The following is a description of a gene set: Genes predicted to be targets of miRBase v22 microRNA mmu_miR_7241_5p in miRDB v6.0 with MirTarget v4 prediction scores > 80 (high confidence targets). studied in species Mus musculus Mouse Gene Set: MIR_7241_5P from publication Chen Y, Wang X (PMID 31504780), and this is the list of marker genes: Ttpal (tocopherol (alpha) transfer protein-like), Zranb2 (zinc finger, RAN-binding domain containing 2), Sass6, H3f3a, Slc26a11, Ssbp3, Cbfb, Cdk6, Tspan2, Nxnl2, Lrrc4c, Pcdh7, Camsap2, Rbak, Med13, Ift43, Rgs7bp, Ube2b, Vps35, Ptbp1, Kdm7a, Tlcd4, Kpna4, Map2k6, Wnk2, Taok1, Vamp4, Calml3, Klf15, Eif2s2, Septin7, Lims1, Scn8a, Clcn5 (NCBI Gene Id 97624), Crmp1, Dpyd, Syt4, Stxbp5l, Stimate (NCBI Gene Id 74250), Dnajb11 (NCBI Gene Id 67838), Sall4, Fam98a, Gpr158, Prkacb, Rfx3, Phospho2, Fam168a, Irx2, Ryr2, H3f5, Nbl1, Mbtd1, Zbtb43, D630045J12Rik, Igf1r, Mdga2, Hpse, Zfp143, Gatad2a, Rtn4, Mon2, Tmem86a, Oog3, Dach1 (NCBI Gene Id 353035), Rictor, Senp5, Smarcd2, Lnpk, Sun1, Rock1, Med11, Pcdh8, Gata6, Chodl